The following is a description of a gene set: species: Homo sapiens Any process that affects the structure and integrity of a protein complex by altering the likelihood of its assembly or disassembly. Human Gene Set: GOBP_REGULATION_OF_PROTEIN_COMPLEX_STABILITY, and this is the list of marker genes: SQSTM1, SNF8, WASHC4, TREX1, SCOC, TRAPPC11, ATG14, ECSIT, NCLN, TAPBP, HSPA8, CSTPP1, IRGM, LUZP1, TBX3, PCM1